The following is a description of a gene set: Genes specifically up-regulated in tumor endothelium. from publication Lu C, Bonome T, Li Y, Kamat AA, Han LY, Schmandt R, Coleman RL, Gershenson DM, Jaffe RB, Birrer MJ, Sood AK (PMID 17308118) Human Gene Set: LU_TUMOR_ENDOTHELIAL_MARKERS_UP Therapeutic strategies based on antiangiogenic approaches are beginning to show great promise in clinical studies. However, full realization of these approaches requires identification of key differences in gene expression between endothelial cells from tumors versus their normal counterparts. Here, we examined gene expression differences in purified endothelial cells from 10 invasive epithelial ovarian cancers and 5 normal ovaries using Affymetrix U133 Plus 2.0 microarrays. More than 400 differentially expressed genes were identified in tumor-associated endothelial cells. We selected and validated genes that were overexpressed by 3.6- to 168-fold using real-time reverse transcription-PCR and/or immunohistochemistry. Among these, the polycomb group protein enhancer of Zeste homologue 2 (EZH2), the Notch ligand Jagged1, and PTK2 were elevated 3- to 4.3-fold in tumor-associated endothelial cells. Silencing these genes individually with small interfering RNA blocked endothelial cell migration and tube formation in vitro. The present study shows that tumor and normal endothelium differ at the molecular level, which may have significant implications for the development of antiangiogenic therapies. studied in species Homo sapiens, and this is the list of marker genes: RPS11, POSTN, VCAN, TNFRSF21, MMP9, PLXDC1, MXRA5, TNFAIP6, CHN1, COL5A3, WDR77, HOPX, ADAP2, LCP2, EGFL6, TWIST1 (NCBI Gene Id 7967), FZD10, PMAIP1, PAMR1, HSPA6, ADAM12, STC1